The following is a description of a gene set: The chemical reactions and pathways resulting in the formation of a deoxyribonucleoside monophosphate, a compound consisting of a nucleobase linked to a deoxyribose sugar esterified with phosphate on the sugar. studied in species Mus musculus Mouse Gene Set: GOBP_DEOXYRIBONUCLEOSIDE_MONOPHOSPHATE_BIOSYNTHETIC_PROCESS, and this is the list of marker genes: Tk1, Dguok, Dut, Dck, Adk, Nme3, Nme1, Dhfr, Shmt2, Nme2, Shmt1, Tk2, Dctd, Tyms